Given this list of marker genes NUP93, ZCCHC24, EFR3B, H1-0, SNRNP25, SERINC1, RSL24D1, PODNL1, HOMER3, TBC1D1, MYH1, JARID2, CBX2, ZNF106, CAMKK2, TSGA10, CD300A, ASIC3, E2F6 (NCBI Gene Id 1876), RALB, GLA, NFE2, LPGAT1, JAK2, CYBB, NLRX1, LIN37, BRD4, TNFRSF1B (NCBI Gene Id 7133), HSPBAP1, RXRA, H1-2, THBS1, CHD5, NXF2, FOSL2, LINC01565, APOBEC3A, UBE2B, ORAI2, SH3GLB2, SFPQ, BCL2A1, MMP25, ABHD2, ZMIZ1, COQ2, RHOBTB3, IGFBP7, ACP3 (NCBI Gene Id 55), OSGIN1, PSMC4, HCLS1, RLF, EPAS1, IL18R1, FTH1, TLE3, IL13RA1, HRH4, CTSS, PIK3C3, C3AR1, PACSIN2, KCNV1, PHACTR1, SZRD1, PTAFR, DCUN1D2, CHMP5 (charged multivesicular body protein 5), SAMD9, AVIL, TGFBR2, RPS6KA1, DCAF7, KDM6B, SKP2, GTF3C5, ISG15, NADK, BCL3, LILRA1, GNAQ, MGAM, ZNF137P, PIK3CB, BTBD7, C1D, SLC6A6, APOBR, SYK, RIN3, H2BC9, MBD4, CCPG1, CXCL2, HYMAI, SORT1, AGGF1, SENP6, PECAM1, PSENEN, RNF144A, MFSD1 (NCBI Gene Id 64747), SRPK1, ASMTL, CD55, LAMTOR5, OSBPL2, MID1IP1, MAP3K3, PGD, MLH1, JOSD1, CA4, ATP6V1B2, PSEN1, RAB5C, SUOX, OSER1, RAB14 (NCBI Gene Id 51730), PIGC, GFOD1, ACACB, POR, ADI1, SYNJ1, PPP2R5B, ETV6, FCGR2C (Fc gamma receptor IIc (gene/pseudogene)), FOS, CHD1, SLC25A23, KBTBD11, PLSCR1, UBE2K, FUCA1, AKT1, ARID3A, ERP44, CENPU, G6PD, GGA2, DDX31, CHRM4 (NCBI Gene Id 1132), LIMK2, CCNT2, RABGEF1, SELPLG, THEMIS2, MTM1, REPS2, HAT1, TKT, DENND4A (NCBI Gene Id 10260), LILRA2, MED28, SLA, MTCP1, RSRP1, LRRFIP1, CYSLTR1, C15orf39, CREG1, SDCBP, PIKFYVE, TMEM156, MYL11, ALOX5, PPP1CB, TST, SMR3B, NAA60 (N-alpha-acetyltransferase 60, NatF catalytic subunit), DAPK1, KCNJ8, CCR3, PKN2, CYB5R4 (NCBI Gene Id 51167), MAML1, ACOT9, GALNT3, ACSL1, RNASET2, CRNKL1, RTN3, SNN, TBL1X, TINF2, TPST1, TRIB1, H2BC12L, CD302, IGF2-AS (IGF2 antisense RNA), TXNRD1, MEF2A, GPN3, PWAR5, DAPK2, USP15, TTC1 (NCBI Gene Id 7265), here is a description of the gene set: studied in species Homo sapiens In the present study we used Affymetrix oligonucleotide microarrays to produce gene transcription profiles for the major leukocyte types in humans. This comprehensive dataset enabled us to not only establish which genes were expressed in each leukocyte type, but also which genes were expressed in each subset after activation. The used of a comprehensive dataset of gene profiles from all the major human leukocyte subsets enabled a novel and powerful means for identification of genes associated with single leukocyte subsets, or different immune paradigms. Human Gene Set: GSE3982_EOSINOPHIL_VS_EFF_MEMORY_CD4_TCELL_UP from publication Jeffrey KL, Brummer T, Rolph MS, Liu SM, Callejas NA, Grumont RJ, Gillieron C, Mackay F, Grey S, Camps M, Rommel C, Gerondakis SD, Mackay CR (PMID 16474395) Genes up-regulated in comparison of eosinophils versus effector memory CD4 T cells.